Given this list of marker genes Gm35309, Rps13, Far1, C430039J01Rik, Coq7, Parvaos, 4933406I18Rik (NCBI Gene Id 71045), Gm5599, Dkk3, Gm4366, Gm18780, Rras2, 1110004F10Rik, Psma1, Gm34225, Sox6os, Galnt18, Bmal1, Gm29507, Gm23229, Gm32676 (predicted gene, 32676), Pde3b, Arl6ip1, Gm23345, Rps4l-ps, Snord14a, AV356131, Smg1, Copb1, Parva, Gm25683, Rassf10, Gm33586, Itpripl2, Usp47, Gm4353, Far1os, Gm33828, Gm44867, 4930583K01Rik, Calcb, 4930543E12Rik, Syt17, Insc, Gm15500, A730082K24Rik (NCBI Gene Id 101786), 2310014F06Rik, Rpl19-ps10, Gm39075, Mical2, Cyp2r1, Nucb2, 1700003G18Rik, Btbd10, Sox6, Gm24154, Gm5600, Xylt1, Gm45588, Pik3c2a, Gm6008, Spon1, Rps15a, 4732496C06Rik, Tead1, Gm32766, Gm18599 (NCBI Gene Id 100417415), Calca, Plekha7, Pth, here is a description of the gene set: Mouse Gene Set: chr7F1 studied in species Mus musculus